The following is a description of a gene set: studied in species Mus musculus from publication Chen Y, Wang X (PMID 31504780) Mouse Gene Set: MIR_6976_5P Genes predicted to be targets of miRBase v22 microRNA mmu_miR_6976_5p in miRDB v6.0 with MirTarget v4 prediction scores > 80 (high confidence targets)., and this is the list of marker genes: Sod3, Fam168a, S1pr2, Surf6, Chia1, Zfp609, Lrrc41, Pbx1, Rraga, Brk1, Hnrnpc, Scn4b, Igf2bp3, Ugt2b1, Magi1, Cbx8, Slc22a23, Slc6a11, Rap2a, Usp54, Crem, Slc10a7, Sp3, Lalba, Eda2r, Rora, Wnt2b, Smpd3, Ccbe1, Casp8, 2310022A10Rik, Ido2, Tmem255a, Slc1a2, Rfx7, Stip1, Sema4c, Ube2a, Tub, Eddm3b, Ccdc157, Patl1 (NCBI Gene Id 225929), Nherf1, Cflar, Jph4, Sart3, Zdhhc8, Morc2a, Pcyt1a, Klhdc10, Dapl1, Tshr, Vldlr, AI597479, Ttbk2, Ocrl, Cdh7, Zfp174, Dtx3l, Shfl, Dcaf7 (NCBI Gene Id 97751), Tpst2, Edem1, Mroh6, Pax6 (paired box 6), C1qtnf1, St3gal2, Map3k9, Kdm7a, Hycc2 (hyccin PI4KA lipid kinase complex subunit 2), Emx1, Ppp2r2d, Spata3, Ogg1, Igf2, Dnajc19, Cfap141, Zbtb7c, Khdc4, Cstf3, Epha4, Gsk3b, Stk35, Arhgef9, Srpk1, Dnajb4, Exd1, Mid2, Fndc5, Sdc1, Slc17a5, Zc3h4, Rab5c, Btrc, Hcfc1r1, Fbxl14, Spata2, Nova2, Cyp4a31, Phactr2, Ston2, Arhgap18, Hcls1, Lss, Dynlrb2, Gdnf, Zdhhc5, Olfml1, Ppm1l, Cxcl16, Stx1b, Sprr2k, Marf1, Rab43, Polh, Vamp2, Pex19 (NCBI Gene Id 19298), Bicral, Trim40, Pak6, Pitpnm1, Cdc25a, Ywhaz, Mllt11, Samd10, Mab21l3, Arih1, Zfp12, Parvb, Nudt15, Tmc2, Slc5a7, Tmem245, Olfml2a, Nsg2, Trp53inp2, H1f0 (NCBI Gene Id 320750), Stox2, Fbxo11 (F-box protein 11), Htr3a, Wasf3